Given this list of marker genes Wnt5a, Abl1, Plekha4, Sfrp1, Rspo1, Wnt5b, Lbx2, Csnk1d, Nkd1, Dab2, Ankrd6, Mllt3, Abl2, Gpc3, Csnk1e, Rspo3, here is a description of the gene set: Any process that activates or increases the frequency, rate or extent of non-canonical Wnt-activated signaling pathway. studied in species Mus musculus Mouse Gene Set: GOBP_POSITIVE_REGULATION_OF_NON_CANONICAL_WNT_SIGNALING_PATHWAY